The following is a description of a gene set: Human Gene Set: HP_COARCTATION_OF_AORTA Coarctation of aorta Coarctation of the aorta is a narrowing or constriction of a segment of the aorta. studied in species Homo sapiens, and this is the list of marker genes: BUB1B, EP300, GLI2, JAG1, NKX2-5, CPLANE1, ELN, ZNF148, SOS2, NF1, HEATR3, CRIPTO, SUCLG1, NR2F2, HRAS, EGFR, SOS1, RPS27, MYH7, TELO2 (telomere maintenance 2), TRIP13, MKS1, CTCF, UNC45B (NCBI Gene Id 191583), KDM5A, DHCR7, SUPT16H, BRAF, CDK8, OSGEP, ALDH18A1, RPS17, SPRED2, NIPA1, RPS29, PUF60, DISP1, MCTP2, MID1, RNU4-2, PGM1, MED12, STRA6, CBL, ZFX, ZEB2, GLI3, SMAD4, EHMT1, SRY, RPS15A, CREBBP, CDON, RPL35A, RPS7, LRPPRC, RAF1, RPS19, ATN1, LZTR1 (leucine zipper like post translational regulator 1), BUB1, PTCH1, RPS28, GAS1, RPS10, WAC, FOXH1, FBLN5, ZIC3, TGDS, RPS24, RBM8A, RPL15, RPS26, GATA1, NOTCH1, FGF8, KDM6A, GATA6, ALG3, RASA2 (RAS p21 protein activator 2), SMAD6, MEIS2, NIPA2, GJA8, TSR2, NAE1, RIT1, ADK, RPL27, FANCB, NAA60, RPL18, PTPN11, RRAS, RPL5, ZIC2, CEP57, TRRAP, GDF1, KRAS, DDX3X, SMARCA2, RNU4ATAC, SHH, PAH, PTH1R, TGIF1, RPL8, MMP2, FLI1, ADA2, DOHH, RPL9 (NCBI Gene Id 6133), FOXF1, RPS20, RPL31, GATA5, WT1, MMP14, TRAF7, MAP2K1, TBX20, CIROP, AMER1, NKX2-6, WDPCP, DLL1, RPL26, SF3B2, GJA5, RPL11, SRCAP, RPL35, SIX3, PPP1CB, ABCD4, FGFR1, TALDO1, NRAS, STAG2, STIL, UBE3B, BUB3, KMT2D, MRAS, CDH2, TUBG1, RRAS2, TBX1, NODAL, DYNC2LI1, CHD4, ABL1